The following is a description of a gene set: Genes up-regulated in CD8 T cells: naïve versus effectors at day 6 after acute infection with LCMV-Armstrong. Human Gene Set: GSE41867_NAIVE_VS_DAY6_LCMV_ARMSTRONG_EFFECTOR_CD8_TCELL_UP species: Homo sapiens During acute viral infections, naïve CD8+ T cells differentiate into effector CD8+ T cells and, after viral control, into memory CD8+ T cells. Memory CD8+ T cells are highly functional, proliferate rapidly upon reinfection and persist long-term without antigen. In contrast, during chronic infections, CD8+ T cells become “exhausted” and have poor effector function, express multiple inhibitory receptors, possess low proliferative capacity, and cannot persist without antigen. To compare the development of functional memory T cells with poorly functional exhausted T cells, we generated longitudinal transcriptional profiles for each. from publication Doering TA, Crawford A, Angelosanto JM, Paley MA, Ziegler CG, Wherry EJ (PMID 23159438), and this is the list of marker genes: ZBTB20, ZNF597, TSPAN13 (tetraspanin 13), SCN3A, IFI27, PPARA, PAX7, HDAC11, LMO7, NAA40, ERLEC1, DMRTB1, TLE1, SELENOP, P2RY10, FAS, ALCAM, S1PR3, C19orf73, RFX7, SMAD1, TUG1, SPAG9 (sperm associated antigen 9), LARS2, MYBPC2, MPP1, MBD2, KDSR, TMF1, CDK17, ERP44, TCF12, DYNLT3, TBCE, STRADB, LAMP2, HPSE, FBXW7, ASAP2, SYNE2, ABCA8, ENPP1, IL1R2, STAMBP, SLFN5, SLC38A1, PPM1D, P2RX2, CTDP1, PPP4R3B, TMEM100, ZNF775, HMGN3, LGMN, TMEM108, RFLNA, ADRA1B, XRCC1, KHDRBS1, MSRA, CPED1, RPL32, GADD45A, WDR37, PAPLN, TRAF6, PDCD1LG2, USP2 (ubiquitin specific peptidase 2), CNST, FGF13, MAPRE2, INPP4B, SMARCA2, STARD4, SAV1, INTS4, GLB1, MYL4, TTC33, TRIM56, DENND5B, HECA, FAM117A, C19orf33, RNF111, CNOT2, TIMM29, ATXN7L1, IRGQ, SFT2D1, GABPA, HSDL2, SPRED1, WWC1, TANC2 (tetratricopeptide repeat, ankyrin repeat and coiled-coil containing 2), RAB21, MYO5A, SLC25A53, TMEM164, CHTOP, TUBG2, VAMP4, GGPS1, GPR65, SCAF4, UBR1 (ubiquitin protein ligase E3 component n-recognin 1), PIK3R1, USP6NL, FBXW2, KLHL24, SUSD1, PARP1, PARP8 (poly(ADP-ribose) polymerase family member 8), MYBL1, FANCL, DNAAF2, TXNDC2, UGCG, ZNF521, STT3B, ETS1, ITGB1BP1, SLC39A6, PLCD3, WFIKKN1, RDH12, MIDEAS, EBAG9, LIMD2, OGFOD3 (NCBI Gene Id 79701), BAZ2B, ANKLE2, MANEA, FOXO1, ACOT9, SLC2A3, AHR, SLC5A1, CCDC30, UCHL3, CHST7, THAP2, LRIG2, DYRK2, DENND2D, SLC35F5, SLAMF7, NUBP1, ST3GAL6, RNF138, TRAPPC8, YPEL2 (NCBI Gene Id 388403), LTBP3, MST1, ATG10 (NCBI Gene Id 83734), CBL, PSD3, CRTC3 (CREB regulated transcription coactivator 3), CCSER2, DNASE1L3, GABPB2, HIVEP3, TBC1D4 (NCBI Gene Id 9882), SAA4, RNF183, LAMP1, PTBP3, MTPN, MACO1, MGA, PPM1F, CECR2, FRAT2, RNF115, LRRC2, COMMD6, CSNK1E, ZNF277, APOBEC1, B3GNT9, ACSL3, CCNI, CRHBP, NRBF2, ZNF383, GAD1, TUBD1, PIMREG, STS, DPP8, IQCB1, MZT1, SLC30A4, CCM2, ZFP36L1, ARMCX2, CMPK1, CDK13, KCTD14, POU1F1